The following is a description of a gene set: studied in species Mus musculus Mouse Gene Set: GOBP_CELLULAR_RESPONSE_TO_INTERLEUKIN_12 Any process that results in a change in state or activity of a cell (in terms of movement, secretion, enzyme production, gene expression, etc.) as a result of an interleukin-12 stimulus., and this is the list of marker genes: Il12a, Il12rb2, Gm36723, Cd47, Sirpa, Jak2, Tyk2, Stat4, Plcb1, Il12rb1, Il12b